The following is a description of a gene set: Cyclin D1 is one of the most commonly overexpressed oncogenes in breast cancer; yet, it is not clear whether cyclin D1 alone is capable of causing malignant transformation of mammary epithelial cells. Here, we show that ectopic expression of cyclin D1 in benign mouse mammary epithelial cells promotes cell proliferation, anchorage-independent growth in soft agar, and tumorigenesis in severe combined immunodeficient mice. To address the possible interaction of cyclin D1 and c-myc in malignant transformation, we used cyclin D1/c-myc dual-expressing clones, which displayed more aggressive and invasive phenotype than cyclin D1-expressing clones. These data provide evidence that overexpression of cyclin D1 or coexpression with c-myc could cause invasive malignant transformation of benign mouse mammary epithelial cells. Furthermore, microarray analysis of cyclin D1 and cyclin D1/c-myc clones showed that these two tumor-producing clones might use distinct invasive pathways. In summary, overexpression of cyclin D1 may commit mammary epithelia to a tumor-prone phenotype in which cooperation with other genes, such as synergy with c-myc, may lead to a more aggressive phenotype. Selected genes changed in NMuMG cells (mammary epithelium) transformed by overexpression of CCND1 vs those transformed by overexpression of CCND1 and MYC. from publication Wang Y, Thakur A, Sun Y, Wu J, Biliran H, Bollig A, Liao DJ (PMID 17440082) studied in species Mus musculus Human Gene Set: WANG_NEOPLASTIC_TRANSFORMATION_BY_CCND1_MYC, and this is the list of marker genes: SERPINB9, TSPAN6, LPAR4, IGFBP5, IGSF5, COL5A3, ARHGAP6, DDIT3, BMF, S100G, EREG, TSPAN7, AREG, MMP12, ATF3, COL5A1, CLSTN2, IGFBP3, IGFBP4, TRIB3, ADAM12, ARHGAP24